Given this list of marker genes ZPR1, TAF8, CHEK1, INTS1, PRPF19, NDEL1, GINS1, BRCA2, GINS4, SBDS, COPS2, PALB2, SALL4, PELO, NCAPG2, here is a description of the gene set: Human Gene Set: GOBP_INNER_CELL_MASS_CELL_PROLIFERATION The proliferation of cells in the inner cell mass. studied in species Homo sapiens